The following is a description of a gene set: species: Mus musculus The process that mediates signaling interactions between one cell and another cell by transfer of current between their adjacent cytoplasms via intercellular protein channels and contributes to the process of cardiac conduction. Mouse Gene Set: GOBP_CELL_COMMUNICATION_BY_ELECTRICAL_COUPLING_INVOLVED_IN_CARDIAC_CONDUCTION, and this is the list of marker genes: Sri, Irx3, Gja5, Pde4d, Tbx5, Gjc1, Hrc, Slc8a1, Gjd3, Cav1 (NCBI Gene Id 12389), Gja1